The following is a description of a gene set: Any process that results in a change in state or activity of a cell or an organism (in terms of movement, secretion, enzyme production, gene expression, etc.) as a result of a forskolin stimulus. Human Gene Set: GOBP_RESPONSE_TO_FORSKOLIN species: Homo sapiens, and this is the list of marker genes: ADCY3, PIM3, ADCY6, GNAI1, CFTR, ADCY2, ADCY5, SLC5A5, FDX1, MIR342, EFNA5, CREB1 (NCBI Gene Id 1385), ADCY1, ADCY8, AHR